The following is a description of a gene set: studied in species Homo sapiens A functional anomaly of the mouth (which is also known as the oral cavity). Abnormal oral physiology Human Gene Set: HP_ABNORMAL_ORAL_PHYSIOLOGY, and this is the list of marker genes: IKZF1, DNASE1, GRIK2, LAMA2, FARS2, SLC9A7, ATP13A2, TAF15, FCGR2B, ZNF365, QDPR, NFIX, GRIN2A, ZBTB16, FIG4, PDCD1, ATP1A3, FUS, ITPR1, ITGAM, HNRNPA1, ATRX, ASAH1, SERPINE1, CTSH, ATP11A, RSRC1, PRX, CR2, FGFR2, SETD5, SNRPN, GLE1, DEAF1, NALCN, CCN2 (cellular communication network factor 2), NRXN1, ANG, HLA-DQB1, MRE11, PXK, RMND1, F2, GRIN1 (glutamate ionotropic receptor NMDA type subunit 1), MAP3K20, MATR3, DAO, CACNA1A (calcium voltage-gated channel subunit alpha1 A), FBLN1, SYNGAP1, SERPING1 (NCBI Gene Id 710), POLR3A (RNA polymerase III subunit A), MED12, EDN1 (NCBI Gene Id 1906), SELENBP1, HOXB1, CAMTA1 (NCBI Gene Id 23261), OCA2, ARX, CLDN10, SNAPC4, EIF2S3, PON1, ADPRS, EXOSC9, GABRA1, LBR (lamin B receptor), SELENON, PFN1, WAS, MEG3, STAT3, GIPC1, FRAS1, PON2, SLC39A14, NEK1, FGFR3, CAV1, HACD1, FBXO28, UBE3A, PRPH, PYROXD1, HERC1 (NCBI Gene Id 8925), IRAK1, TUBB2B, PPARGC1A, NONO, SATB2, SYT2, MT-CO3, IDS, LNPK, JAZF1 (NCBI Gene Id 94314), IGHG1, BLK, PPP2R5D, NPM1, CCR6, AHDC1, ATXN2, RNU4-2, SATB1, ADNP, SLC16A2, PLCB4, SLC12A2, GLT8D1, ZC4H2, RARA, IRF5, SQSTM1, MYL2 (myosin light chain 2), PRRT2, KCNC2, TNFAIP3, ATP7B, UNC13A, SLC52A2, UBQLN2, CACNA1I, NOD2, KCNK9, CHRM3, SCNN1G, SLC9A6, WNK1, FGFR1, KIF15, PLA2G6, NEUROG1, F8, CHMP2B, ELOVL1, SCN9A, EXOSC3, TNFSF4, F13B, GNS, MED27, MAT1A, P2RY11, H4C5, TP63, ITGA7, PYGM, PMP22, ADSS1, GFM2, ADGRG1, MTRFR, F13A1, TUBB4A, VAPB, NEFH, RACGAP1, PAX9 (paired box 9), FGF10, GRIN2D, VCP, SLC25A12, TTI1, HCRT, RETREG1, EDARADD, SPTSSA, SOD1, MAGEL2, IL10, RAB11B, AP4S1, ACTA1, PTPA, ZBTB11, TSPYL1, STAT5B, TASP1, TRANK1, GABRG2, F10, FCGR3B, CFTR, ALS2 (alsin Rho guanine nucleotide exchange factor ALS2), MBD5, DLAT, TLR7, SCNN1B, APOLD1 (apolipoprotein L domain containing 1), MECP2, UBA1, PTPN22, HLA-DRB1, TPM2, EXOSC8, ATP10A, NABP1, ELP1, KIF7, SUMO1, CHRNA1, GSN, PRKAR1A, PRPS1, AP4M1, NDUFS4, SLC25A21, LPIN1, VAC14 (VAC14 component of PIKFYVE complex), GABBR2, MEGF10 (multiple EGF like domains 10), AIFM1, CTLA4, SPTBN1, SLC52A3, SCN2A, KIF1A, ZEB2, SMARCA2, SH3TC2, HPDL, PON3, CHAMP1, DDC, TSPOAP1, TPM3, SCNN1A, TAF4, SCN1B, KIAA0319L, LGI3, NTRK1, PML (PML nuclear body scaffold), VPS13A, STAT4, ANKLE2, TBCD, PCGF2, VRK1, TNIP1, CHCHD10, SPEN, WNT10A, HDAC4, PIGL, FOXP1, MT-CO1, HIVEP2, P4HA2, RILPL1, TGFA, MOG, HLA-B, CFAP410, NEXMIF, RTL1, UBE2L3, TBK1, TREM2, GAA, HNRNPH2, MTPAP, ERBB4, AGTPBP1, STRADA, ATP6AP2, DLK1, TBX1, C4A, TANGO2, SPTLC1, NUMA1, BCORL1, SLC39A4, TBL1XR1, TUBB3, PI4KA, SMN1, BANK1, NAA20, POLR3B, GNAI3, NOTCH2NLC, NAXD, ETS1, SPP1, PDE10A, BCOR, AP4B1, ATP1A2, SLC25A46, LMNB2, COLQ, POU3F3, TREX1, C4B, TOE1 (NCBI Gene Id 80147), POLG, FXR1, GCH1, WNT10B, SHMT2, GPT2, PCDH19 (protocadherin 19), EXTL3, FOXG1, CLDN11, PAK3, MTHFS, AP4E1, SLC12A5, IRF2BP2, OBSCN, PRUNE1, SMN2, EDA (NCBI Gene Id 90878), IRF6, NTNG2, EGR2, MSX1, SCN1A, CERT1, FOXP2, NOP56, F5, CCNF, DNM1L, TARDBP, VWA1, KANSL1, LAMB2, SBF2, PTS, SLC1A4, ANXA11 (NCBI Gene Id 311), FIP1L1 (NCBI Gene Id 81608), TH, LRP12, AXIN2, SPART, NECTIN1, MPZ, DCTN1, KIF23, LRP6, OPTN, SRPX2, SIM1